The following is a description of a gene set: The restriction of influenza A virus replication to mouse respiratory epithelium means that this host response is anatomically compartmentalized, on the one hand, to sites of T cell stimulation and proliferation in the secondary lymphoid tissue and, on the other hand, to the site of effector T cell function and pathology in the pneumonic lung. Thus, it is hardly surprising that virus-specific CD8(+) T cells recovered by bronchoalveolar lavage (BAL) from the infected respiratory tract seem more activated in terms of both cytolytic activity and cytokine production than those cells isolated from the spleen. The present analysis uses Affymetrix microarray technology to compare profiles of gene expression in these two lineage-related, yet anatomically separate, lymphocyte populations. Ninety differentially expressed genes were identified for influenza-specific CD8(+)D(b)NP(366)(+) T cells obtained directly ex vivo by BAL or spleen disruption, with nine genes being further analyzed by quantitative, real-time PCR at the population level. Integrin alphaE, for example, was shown by Affymetrix and real-time mRNA analyses and then by single-cell PCR and protein staining to be present at a much higher prevalence on the BAL CD8(+)D(b)NP(366)(+) set. The unpredicted finding, however, was that mRNA expression for 75% of the genes was lower in T cells from the BAL than from the spleen. Apparently, the localization of virus-specific CD8(+) T cells to the site of virus-induced pathology is associated with a narrowing, or focusing, of gene expression that favors enhanced effector function in the damaged, high-antigen load environment of the pneumonic lung. Genes down-regulated in the influenza-specific CD8+ T lymphocytes from bronchoalveolar lavage (BAL) compared to those from spleen. Mouse Gene Set: MARSHALL_VIRAL_INFECTION_RESPONSE_DN species: Mus musculus from publication Marshall DR, Olivas E, Andreansky S, La Gruta NL, Neale GA, Gutierrez A, Wichlan DG, Wingo S, Cheng C, Doherty PC, Turner SJ (PMID 15831586), and this is the list of marker genes: Rasa3, Gzmb, Il18rap, Sgk1, Ccl9, S1pr4, Pdlim1, Klf3, Stat5b, Txk, Cks2, Dtx1, Kif23, Relb, Tcf7, Ly6c2, Klf2, Gzma, Tob1, Gabpb1, Nfkbia, H2az1, Itgb7 (integrin beta 7), Myb, Pcna, Cd7, Nfkbib, Pim1, Tgif1, Klrg1